Given this list of marker genes WHRN, ADGRV1, USH2A, PDZD7, USH1C, VEZT, here is a description of the gene set: A complex of proteins that connect growing stereocilia in developing cochlear hair cells, composed of Vlgr1, usherin, vezatin, and whirlin. Human Gene Set: GOCC_STEREOCILIA_ANKLE_LINK_COMPLEX species: Homo sapiens